The following is a description of a gene set: 11-cis-retinol dehydrogenase (RDH5) can reversibly catalyse the oxidation of all-trans-retinol (atROL, bound to RLBP1) to all-trans-retinal (atRAL) in retinal pigment epithelium (RPE) cells using NAD+ as cofactor. Defective RDH5 causes retinitis punctata albescens (RPA, also called fundus albipunctatus, FA; MIM:136880). RPA (an autosomal recessive disorder) is a form of stationary congenital night blindness characterised by a reduced regeneration rate of rod and cone photoreceptors and yellow-white lesions within the retina or the RPE. For review, please refer to Zeitz et al. 2015. studied in species Homo sapiens part of: Retinoid cycle disease events Reactome Pathway: Defective visual phototransduction due to RDH5 loss of function, and this is the list of marker genes: RDH5, RLBP1